Given this list of marker genes FOCAD (NCBI Gene Id 54914), ATP5F1A, MT-TV, SLC25A4, NDUFB10, MMACHC, DNM1L, POLG, ATP5MK, PDHA1, MTO1, GAMT (NCBI Gene Id 2593), MT-ND4, ATP5F1D, SLC7A7, COQ9, MT-ND1, LIG3, MT-TL1, ALDH4A1, MRPS2, ATP5F1E, TMEM70 (NCBI Gene Id 54968), PRDX1, BCKDHA, NGLY1, UQCRC2, SCO1, LMBRD1, PC, TARS2, SERAC1, VARS2, CTH, PDHX, HS6ST2, TMEM126B, FBXL4, MRPL39, PDP1, ASPA, SLC25A13, COX5A, TRMT10C, KARS1, MICOS13, COX10, MRPS14, CA5A (carbonic anhydrase 5A), NDUFS4, MT-ND5, DTYMK, COX6B1, MT-ATP6, MT-TW, MT-TK, OPA1, MT-ND2, FBP1, LYRM7, COX8A, MT-ATP8, NAGS, MIPEP, TEFM (NCBI Gene Id 79736), TYMP, MT-ND6, NDUFC2, NDUFA13, MRPL3 (mitochondrial ribosomal protein L3), MTHFR, RRM2B, MT-ND3, LIPT2, COX16, ATPAF2, NFS1, here is a description of the gene set: Human Gene Set: HP_ABNORMAL_CIRCULATING_PROTEINOGENIC_AMINO_ACID_DERIVATIVE_CONCENTRATION Abnormal circulating proteinogenic amino acid derivative concentration Any deviation from the normal concentration in the blood circulation of a compound that is derived from an amino acid. studied in species Homo sapiens